Given this list of marker genes Vegfc, Nedd9, Timp1, Pdgfrb, Thbs2, Loxl3, Dcn, Wnt2, Loxl1, Mmp2, Itgbl1 (integrin, beta-like 1), Lum, Ncam1, Cxcl13, C2 (NCBI Gene Id 12263), Fn1, Fgfr1, here is a description of the gene set: Germline mutation in serine/threonine kinase 11 (STK11, also called LKB1) results in Peutz-Jeghers syndrome, characterized by intestinal hamartomas and increased incidence of epithelial cancers. Although uncommon in most sporadic cancers, inactivating somatic mutations of LKB1 have been reported in primary human lung adenocarcinomas and derivative cell lines. Here we used a somatically activatable mutant Kras-driven model of mouse lung cancer to compare the role of Lkb1 to other tumour suppressors in lung cancer. Although Kras mutation cooperated with loss of p53 or Ink4a/Arf (also known as Cdkn2a) in this system, the strongest cooperation was seen with homozygous inactivation of Lkb1. Lkb1-deficient tumours demonstrated shorter latency, an expanded histological spectrum (adeno-, squamous and large-cell carcinoma) and more frequent metastasis compared to tumours lacking p53 or Ink4a/Arf. Pulmonary tumorigenesis was also accelerated by hemizygous inactivation of Lkb1. Consistent with these findings, inactivation of LKB1 was found in 34% and 19% of 144 analysed human lung adenocarcinomas and squamous cell carcinomas, respectively. Expression profiling in human lung cancer cell lines and mouse lung tumours identified a variety of metastasis-promoting genes, such as NEDD9, VEGFC and CD24, as targets of LKB1 repression in lung cancer. These studies establish LKB1 as a critical barrier to pulmonary tumorigenesis, controlling initiation, differentiation and metastasis. studied in species Mus musculus Mouse Gene Set: JI_CARCINOGENESIS_BY_KRAS_AND_STK11_DN from publication Ji H, Ramsey MR, Hayes DN, Fan C, McNamara K, Kozlowski P, Torrice C, Wu MC, Shimamura T, Perera SA, Liang MC, Cai D, Naumov GN, Bao L, Contreras CM, Li D, Chen L, Krishnamurthy J, Koivunen J, Chirieac LR, Padera RF, Bronson RT, Lindeman NI, Christiani DC, Lin X, Shapiro GI, Jänne PA, Johnson BE, Meyerson M, Kwiatkowski DJ, Castrillon DH, Bardeesy N, Sharpless NE, Wong KK (PMID 17676035) Cluster B: genes down-regulated in primary lung tumors driven by KRAS activation and loss of STK11; also up-regulated in human squamous cell carcinoma (SCC) vs adenocarcinoma subtype of NSCLC (non-small cell lung cancer).